The following is a description of a gene set: part of: Influenza Viral RNA Transcription and Replication Reactome Pathway: Viral Messenger RNA Synthesis Like the mRNAs of the host cell, influenza virus mRNAs are capped and polyadenylated. The methylated caps, however, are scavenged from host cell mRNAs and serve as primers for viral RNA synthesis, a process termed 'cap-snatching'. The PB2 polymerase protein binds the cap, activating endonucleolytic cleavage of the host mRNA by PB1. The 3' poly-A tracts on viral messages are generated by polymerase stuttering on poly-U tracts near the 5' end of the template vRNA. The second process allows polyadenylation of viral mRNAs when the host cell polyadenylation process has been inhibited. Notably, early transcripts (including NP and NS1) accumulate in the cytoplasm before late transcripts (M1, HA, and NS2), and in varying abundances, suggesting additional control mechanisms regulating viral gene expression. studied in species Homo sapiens, and this is the list of marker genes: NUP153 (NCBI Gene Id 9972), SEH1L, NUP98, NUP62, NUP85, POLR2J, AAAS, POLR2B, POLR2C, POLR2I, NUP50, POM121C, PA, NUP107, NUP188, NUP54, NDC1, PB1, SEC13, POM121, POLR2K, POLR2F, POLR2H, TPR, NUP37, NUP210, POLR2E, POLR2A, NUP214 (nucleoporin 214), NUP93, NUP155, PB2, NUP58, GTF2F2, NUP35, NUP160, NUP88, RANBP2, GTF2F1, RAE1, NUP205, NP, POLR2L, NS, NUP133, POLR2G, NUP43 (nucleoporin 43), NUP42 (NCBI Gene Id 11097), POLR2D